The following is a description of a gene set: Genes predicted to be targets of miRBase v22 microRNA mmu_miR_7679_5p in miRDB v6.0 with MirTarget v4 prediction scores > 80 (high confidence targets). from publication Chen Y, Wang X (PMID 31504780) studied in species Mus musculus Mouse Gene Set: MIR_7679_5P, and this is the list of marker genes: Cdyl, Adcy6, Ube2w, Elp3, Car7, Bcl11a, Inpp5d, Phf24, Cplx2, Sarm1, Spred3, Rapgef2, Phf21a, Prr5, Aak1, Cdk2, Pdpk1, Wwp1, Snx15 (sorting nexin 15), Septin4, Ddx19b, Ptpn2, Cadm4, Carhsp1, Ccl22, Elk1, Ephx2, Slc17a5, Hectd1, Dnase1l3, Sorbs2, Rhoj, 4930563E22Rik, Ciita, Vps11, Zdhhc8, Rgl2 (NCBI Gene Id 19732), Pappa2, Adcy1, Tbc1d24, Add1 (adducin 1), Dgkd, Uvssa, Kcnc2, Rab11fip1 (NCBI Gene Id 75767), Ranbp3, Nectin2, Igdcc4, Gdf2, Armc9, Rspry1, Tmem150a, Tpd52l2, Pcid2, Sema4g, Dll4, Fzd7, Cd247, Rab11b, Ube4b, Clock, Smpd3, Nf2, Ndst1, Hadh (hydroxyacyl-Coenzyme A dehydrogenase), Slc25a39 (NCBI Gene Id 68066), Bach2, Srf, Acta1, Zim1, Kcnq4, Ascc2, Mpeg1, Oas1a, Rmi2, Cbfa2t3, Osbp2, Chrdl1, Slx9, Shroom4, Megf11, Nkd1, Oas1g, Dnajb12, Abhd4, Trem6l, Tmem52, Dlg2, Ttyh3, Prrt2, Hecw2, 2210408I21Rik, Mief2, Igf2bp2, Rhoq, Wdr20, Ptgs1, Alkbh5, Msrb1, Atg4b, Arhgef15, Smad3, Mmp24, Ralb, Des, Slc38a6 (solute carrier family 38, member 6), Lrrc39, Crcp, Napb, Rere, Son, Lrrc20, Eef2k, Fbxl9